Given this list of marker genes Mcts1, Ssb, Shfl, Eif3l (NCBI Gene Id 68333), Eif3a, Eif2d, Atg12, Oaz2 (ornithine decarboxylase antizyme 2), Eif2ak4, Eif3g, Denr, Oaz3, Pcbp2, Eif3d, Ptbp1, Paip1, Eif3b, Peg10, Atg5 (autophagy related 5), Csde1, Eif3f, Oaz1, here is a description of the gene set: Mouse Gene Set: GOBP_VIRAL_TRANSLATION species: Mus musculus A process by which viral mRNA is translated into viral protein, using the host cellular machinery.